The following is a description of a gene set: studied in species Mus musculus The process in which the anatomical structure of the optic nerve is generated and organized. The sensory optic nerve originates from the bipolar cells of the retina and conducts visual information to the brainstem. The optic nerve exits the back of the eye in the orbit, enters the optic canal, and enters the central nervous system at the optic chiasm (crossing) where the nerve fibers become the optic tract just prior to entering the hindbrain. Mouse Gene Set: GOBP_OPTIC_NERVE_MORPHOGENESIS, and this is the list of marker genes: Chrnb2, Gli3, Ephb1, Ephb2, Kcna2, Pax2